Given this list of marker genes NCAM1, ATP5PO, DPP8, ATP5MG, ATF4, UQCRC2, PF4, KCMF1, GUCY1B1, MMD, NENF, PSMD2, CLPB (ClpB family mitochondrial disaggregase), NDUFB5, ENDOD1, PFDN5, MXI1, AHCYL1, ALDH6A1, SEPTIN2, CTSK (NCBI Gene Id 1513), YARS1, COPS2, MYL9, HGD (homogentisate 1,2-dioxygenase), UGP2, MGLL, PGRMC1, RAB9A, ABCB7, KIF11, LY6H, CFLAR, MFAP3L, SMG1, RBBP6, NACA, S100A10, PDGFA, COX5A, IFI44L, ZMAT3, PSMA6, TMEM8B, NRGN, LY86, VCL, C3, OXA1L, ME2, RRAGC, MCTS1, BTF3, PBX3, SERP1, P2RX7, UBE2L3, RNASEH1, CLNS1A, ZNF277, CTTN, PTGS1, ITGA2B, NDUFA9, MYLK, F13A1, CRYL1, LAP3, SCAF4, PRKAR2B, TAX1BP1, EIF3E, RFTN1, UBE2D2, TAP2, GUCY1A1, TENT5A, AP1S2 (adaptor related protein complex 1 subunit sigma 2), BTF3P12, CMC4, MRPS15, TAOK3, TUBB1, CELF2, ITGB5, ARL6IP5, TNIK, CPNE3, STX8, EFHC2, TEP1, TMEM97, SMAD7, DMAC2L, ANXA4, MAPKAPK5, SMAD1, MSH3, C1orf54, ASAP2, KYAT3, COX7A2, SUMO3, PSME1, UQCRB, CALCOCO2, SERINC3, HMGXB4, SNX4, SERTAD2, SOX4, SKAP2, NDRG2, DNM1L, BIN2, IFI27 (interferon alpha inducible protein 27), PEX26, GMPS, GDI2, PTGIR, HEBP1, MCCC1, HIGD1A, GNAZ, IK, IL12RB2, IGF2BP3, COPA, IL1A, NDUFS4, CNOT7, OLA1, PLPBP, JTB, ASL, IQCG, UCHL3, PSMA1, AUTS2, DAB2, IGFBP7, RO60, PARL, PABPC1, REPS1, COLQ, DLG1, PTP4A2, ZNF185, ARHGEF10L, ATP5F1C, SUCLG1, ARHGAP6 (NCBI Gene Id 395), CLU, PPBP, SNX6, PSTPIP2, CAST, HLA-DQB1, ASXL2, ZNF91, ZBTB20, PROS1 (NCBI Gene Id 5627), STYXL1 (NCBI Gene Id 51657), PTER, MTARC2, CHMP4A (charged multivesicular body protein 4A), RNF115, XAF1, XK, TDRD3, ZBTB16, ERVMER34-1, RWDD1, MYH6, GLG1, SLC25A5 (NCBI Gene Id 292), NCOA2, AKR7A2, TRIAP1, TPM1, KLC1, SFXN1, ATMIN, ALOX12, MRPS10, LPP, MYG1, NREP, MT1X, KIAA0319L, CD99, HTATIP2, LEPROT, MCUR1 (NCBI Gene Id 63933), GNG11, FHL1, SMAD2, here is a description of the gene set: Objective: We hypothesized that type 1 diabetes (T1D) is accompanied by changes in gene expression in peripheral blood mononuclear cells (PBMCs) due to dysregulation of adaptive and innate immunity, counterregulatory responses to immune dysregulation, insulin deficiency and hyperglycemia. Research Design and Methods: Microarray analysis was performed on PBMCs from 43 patients with newly diagnosed T1D, 12 patients with newly diagnosed type 2 diabetes (T2D) and 24 healthy controls. One and four month follow-up samples were obtained from 20 of the T1D patients. Results: Microarray analysis identified genes differing in expression between newlydiagnosed T1D patients and controls at a false discovery rate of 0.05. Changes in expression of interleukin-1β (IL1B), early growth response gene 3 (EGR3), and prostaglandin-endoperoxide synthase 2 (PTGS2) resolved within four months of insulin therapy and were also observed in T2D suggesting that they resulted from hyperglycemia. With use of a knowledge base, 81/genes could be placed within a network of interrelated genes with predicted functions including apoptosis and cell proliferation. IL1B and the MYC oncogene were the most highly-connected genes in the network. IL1B was highly overexpressed in both T1D and T2D, whereas MYC was dysregulated only in T1D. Conclusion: T1D and T2D likely share a final common pathway for beta cell dysfunction that includes secretion of interleukin-1β and prostaglandins by immune effector cells, exacerbating existing beta cell dysfunction, and causing further hyperglycemia. The results identify several targets for disease-modifying therapy of diabetes and potential biomarkers for monitoring treatment efficacy. from publication Kaizer EC, Glaser CL, Chaussabel D, Banchereau J, Pascual V, White PC (PMID 17595242) studied in species Homo sapiens Genes up-regulated in comparison of peripheral blood mononuclear cells (PBMC) from healthy donors versus PBMCs from patients with type 1 diabetes at the time of diagnosis. Human Gene Set: GSE9006_HEALTHY_VS_TYPE_1_DIABETES_PBMC_AT_DX_UP